The following is a description of a gene set: species: Mus musculus The liver, skin, and gastrointestinal tract are major target organs of acute graft-versus-host disease (GVHD), the major complication of allogeneic bone marrow transplantation (BMT). In order to gain a better understanding of acute GVHD in the liver, we compared the gene expression profiles of livers after experimental allogeneic and syngeneic BMT using oligonucleotide microarray. At 35 days after allogeneic BMT when hepatic GVHD was histologically evident, genes related to cellular effectors and acute-phase proteins were up-regulated, whereas genes largely related to metabolism and endocrine function were down-regulated. At day 7 after BMT before the development of histologic changes in the liver, interferon gamma (IFN-gamma)-inducible genes, major histocompatibility (MHC) class II molecules, and genes related to leukocyte trafficking had been up-regulated. Immunohistochemistry demonstrated that expression of IFN-gamma protein itself was increased in the spleen but not in hepatic tissue. These results suggest that the increased expression of genes associated with the attraction and activation of donor T cells induced by IFN-gamma early after BMT is important in the initiation of hepatic GVHD in this model and provide new potential molecular targets for early detection and intervention of acute GVHD. Hepatic graft versus host disease (GVHD), day 7: up-regulated in allogeneic vs syngeneic bone marrow transplant. from publication Ichiba T, Teshima T, Kuick R, Misek DE, Liu C, Takada Y, Maeda Y, Reddy P, Williams DL, Hanash SM, Ferrara JL (PMID 12663442) Human Gene Set: ICHIBA_GRAFT_VERSUS_HOST_DISEASE_D7_UP, and this is the list of marker genes: SERPINA10, HLA-DRA, ORM1, IL18R1, MARCO, ISG15, NFKBIA, CYBA, STAT1, PKM, SLC11A1, CCL7, LITAF, IL1RN, FKBP11, TAPBP, HLA-DMA, BCL2A1, PLAC8, RNF19B, SNX10, IFI16, CCL2 (C-C motif chemokine ligand 2), TMSB10, HLA-DMB, WARS1, SAAL1, MAK16, CD74, EOGT, ICAM1, N4BP1, PSMB9, SOCS1, CRYAA, IRGM, PSMB10, PYHIN1, LBP, RPS6KC1, C8orf33, ITPK1, CXCL10, SERPINA3, IL18BP, GBP4, PSME1, IFIT3, KRT18, LY75 (lymphocyte antigen 75), CD53, MT1F, NFKBIZ, SHISA5, IL6ST, CLIC1, CRYBG1, MPEG1, C1QB, ADGRE1, MIR191, USP18, RNASE3, C1QC, PTPN1, IRF8, ATP11A, TAP1, HLA-DRB1, CD5L, LYZ, CXCL9, COL4A1, IRF1, PTGS1, CCL23, PLD4, IFIT1B, NAMPT, SAMHD1, CDC42SE2, UBA7, PROCR, XDH, CD14, LCP2, VCAM1, CTSS, HCK, TMSB4X, PSMB8, LGALS3BP, IFI27, GIMAP4, HLA-DQA2, FGL2, PSME2, GBP2, IRF7 (NCBI Gene Id 3665), NEK9, TFF3, FLOT1, AKAP9, TYROBP, ZIC3, LY86, FAS, MSR1, FKBP5, IFI35, EIF1AY, TAP2, PLD3, HLA-DQB1